Given this list of marker genes H3C15, PRIM2, H2BC21, CAPNS2, CAPNS1, UL36, SUZ12, H2BC11, LMNA, APP, H2AJ, FASLG, H2AC4, NS, H2BC17, H3-3A, BCL2L11, RBBP4 (RB binding protein 4, chromatin remodeling factor), RBBP7, DNMT1, H2BC5, C1QBP, CAST, H2BC26, FADD, H2BC14, H2BC12L, JUN, TRAF2, EZH2, H2BC9, H2AZ2, TRADD, H2AC14, RIR1, H2AC6, H2AB1 (H2A.B variant histone 1), CDK5R1, EED, H2AC20, FOXO3 (NCBI Gene Id 2309), POLA1, H2BC1, CDC25C, SOD2, PRDX2, RIPK3, PRDX1, H4C1, MLKL (NCBI Gene Id 197259), 3a, PRIM1, OPG199, TP53, CDK5, H2BC3, H3C1, H2AC18, CAPN2, CDC25B, H2AX, CDC25A, H2AC7, RIPK1, POLA2, DNMT3A, H2BC13, LMNB1, H2BC4, DNMT3B, CAPN1, GOLGA2, YWHAE, GSDME, H2BC12, CDKN2A, CASP8, H2BC15, here is a description of the gene set: part of: Disease Reactome Pathway: Diseases of programmed cell death Programmed cell death is frequently impaired in cancer and is thought to significantly contribute to resistance to chemotherapy. Mutations and perturbations in expression of different proteins involved in programmed cell death, such as TP53 (p53), BH3-only family proteins, caspases and their regulators enable malignant cells to evade apoptosis. studied in species Homo sapiens